The following is a description of a gene set: studied in species Mus musculus Mouse Gene Set: SHANK_TAL1_TARGETS_DN Analysis of the INK4A/ARF locus in human T-ALL patients revealed frequent deletions in exon 2, the exon common to both p16(INK4A) and p14(ARF). Other studies have described selective deletion of exon 1beta of p14(ARF) or methylation of the p16(INK4A) promoter. Therefore, it is unclear from these studies whether loss of p16(INK4A) and/or p14(ARF) contributes to the development of T-ALL. To elucidate the relative contribution of the ink4a/arf locus to T-cell leukemogenesis, we mated our tal1 transgenic mice to ink4a/arf-/-, p16(ink4a)-/-, and p19(arf)-/- mice and generated tal1/ink4a/arf+/-, tal1/p16(ink4a)+/-, and tal1/p19(arf)+/- mice. Each of these mice developed T-cell leukemia rapidly, indicating that loss of either p16(ink4a) or p19(arf) cooperates with Tal1 to induce leukemia in mice. Preleukemic studies reveal that Tal1 expression stimulates entry into the cell cycle and thymocyte apoptosis in vivo. Interestingly, mice expressing a DNA-binding mutant of Tal1 do not exhibit increases in S phase cells. The S phase induction is accompanied by an increase in thymocyte apoptosis in tal1 transgenic mice. Whereas apoptosis is reduced to wild-type levels in tal1/ink4a/arf-/- mice, S phase induction remains unaffected. Thus, Tal1 stimulates cell cycle entry independent of the ink4a/arf locus, but its ability to induce apoptosis is Ink4a/Arf-dependent. from publication Shank-Calvo JA, Draheim K, Bhasin M, Kelliher MA (PMID 16407836) Genes down-regulated in preleukemic thymocytes from transgenic mice which overexpress TAL1 in thymus., and this is the list of marker genes: Cd4, Cd5, Id2 (inhibitor of DNA binding 2), Rag2, Ptcra, Rag1, Bcl2, Cd6, Rorc, Bcl2l1 (NCBI Gene Id 12048)